Given this list of marker genes Vpreb3, Ccr7, Cd52, Fcer2a, Fos, Stk17b, Cxcr4, here is a description of the gene set: Cytokines mediate cell-cell communication in the immune system and represent important therapeutic targets. A myriad of studies have highlighted their central role in immune function, yet we lack a global view of the cellular responses of each immune cell type to each cytokine. To address this gap, the authors created the Immune Dictionary, a compendium of single-cell transcriptomic profiles of more than 17 immune cell types in response to each of 86 cytokines (>1,400 cytokine-cell type combinations) in mouse lymph nodes in vivo. A cytokine-centric view of the dictionary revealed that most cytokines induce highly cell-type-specific responses. For example, the inflammatory cytokine interleukin-1β induces distinct gene programmes in almost every cell type. A cell-type-centric view of the dictionary identified more than 66 cytokine-driven cellular polarization states across immune cell types, including previously uncharacterized states such as an interleukin-18-induced polyfunctional natural killer cell state. from publication Cui A, Huang T, Li S, Ma A, Pérez JL, Sander C, Keskin DB, Wu CJ, Fraenkel E, Hacohen N (PMID 38057668) Mouse Gene Set: CUI_B_CELL_IL18_RESPONSE_DN Genes negatively differentially expressed in cell type: B cell upon treatment with cytokine: IL-18 in mouse lymph nodes in vivo. species: Mus musculus